Given this list of marker genes PCCA, PAH, PCCB, HMGCL, BCKDHA, here is a description of the gene set: An increase in the level of hippuric acid in the urine. studied in species Homo sapiens Increased level of hippuric acid in urine Human Gene Set: HP_INCREASED_LEVEL_OF_HIPPURIC_ACID_IN_URINE